The following is a description of a gene set: species: Mus musculus Reactome Pathway: Interleukin-2 family signaling part of: Signaling by Interleukins This event has been computationally inferred from an event that has been demonstrated in another species.<p>The inference is based on the homology mapping from PANTHER. Briefly, reactions for which all involved PhysicalEntities (in input, output and catalyst) have a mapped orthologue/paralogue (for complexes at least 75% of components must have a mapping) are inferred to the other species. electronically inferred by orthology from the curated human pathway, and this is the list of marker genes: Jak3, Il2rb, Il9r, Ptpn6 (protein tyrosine phosphatase, non-receptor type 6), Stat5b, Il2ra, Il5, Il3, Stat5a, Il21r, Stat4, Csf2, Il2rg, Csf2rb, Syk, Sos2, Pik3cb, Il2, Pik3r2, Il5ra, Shc1, Il15, Inppl1, Il9 (interleukin 9), Lck, Grb2, Il21